The following is a description of a gene set: Reactome Pathway: Synthesis of bile acids and bile salts via 27-hydroxycholesterol part of: Synthesis of bile acids and bile salts species: Homo sapiens In the body, 27-hydroxycholesterol is synthesized in multiple tissues, exported to the liver, and converted there to bile acids and bile salts. This pathway is only a minor source of bile acids and bile salts, but may play a significant role particularly in the mobilization of cholesterol from lung phagocytes.<p>In the liver, conversion of 27-hydroxycholesterol to bile acids and bile salts is initiated with hydroxylation and oxidoreductase reactions to form 4-cholesten-7alpha,27-diol-3-one. The pathway then branches: hydroxylation of 4-cholesten-7alpha,27-diol-3-one to 4-cholesten-7alpha,12alpha,27-triol-3-one leads ultimately to the formation of cholate, while its reduction to 5beta-cholestan-7alpha,27-diol-3-one leads to chenodeoxycholate formation. In both branches, reactions in the cytosol, the mitochondrial matrix, and the peroxisomal matrix result in modifications to the ring structure, shortening and oxidation of the side chain, conversion to a Coenzyme A derivative, and conjugation with the amino acids glycine or taurine. These reactions are outlined in the figure below. The final nine reactions are identical to ones of bile salt synthesis initiated by 7alpha-hydroxylation and are shown as arrows with no substrates., and this is the list of marker genes: RXRA, CYP8B1, AKR1D1, NCOA1, AKR1C4, CYP27A1, AKR1C3, AKR1C2, NCOA2, NR1H4, HSD3B7, AKR1C1, CYP7B1, CYP7A1